Given this list of marker genes STAT5A, STAT5B, JAK1, STAT1, IL22RA1, PTPN11, IFNLR1, JAK3, IFNL2, SOCS3, IL10RB, STAT2, STAT4, IL26, IL24, IL20RA, IL20, IL20RB, IL22RA2, IL19, STAT3, TYK2, IFNL1, IFNL3, IL22, JAK2 (Janus kinase 2), here is a description of the gene set: Human Gene Set: REACTOME_INTERLEUKIN_20_FAMILY_SIGNALING Interleukin-20 family signaling species: Homo sapiens